The following is a description of a gene set: from publication Lee JS, Scandiuzzi L, Ray A, Wei J, Hofmeyer KA, Abadi YM, Loke P, Lin J, Yuan J, Serreze DV, Allison JP, Zang X (PMID 22972920) Genes up-regulated in pancreatic CD8 T cells from mice with: type 1 diabetes mellitus versus healthy controls. B7x (B7-H4 or B7S1) is the seventh member of the B7 family and the in vivo function remains largely unknown. Despite new genetic data linking the B7x gene with autoimmune diseases, how exactly it contributes to peripheral tolerance and autoimmunity is unclear. Here we showed that B7x protein was not detected on antigen-presenting cells or T cells in both human and mice, which is unique in the B7 family. As B7x protein is expressed in some peripheral cells such as pancreatic b cells, we utilized a CD8 T cell-mediated diabetes model (AI4ab) in which CD8 T cells recognize an endogenous self-antigen, and found that mice lacking B7x developed more severe diabetes than control AI4ab mice. Conversely, mice overexpressing B7x in the b cells (Rip-B7xAI4ab) were diabetes free. Furthermore, adoptive transfer of effector AI4ab CD8 T cells induced diabetes in control mice, but not in Rip-B7xAI4ab mice. Mechanistic studies revealed that pathogenic effector CD8 T cells were capable of migrating to the pancreas but failed to robustly destroy tissue when encountering local B7x in Rip-B7xAI4ab mice. Although AI4ab CD8 T cells in Rip-B7xAI4ab mice and AI4ab mice showed similar cytotoxic function, cell death, and global gene expression profiles, these cells had greater proliferation in AI4ab mice than in RIP-B7xAI4ab mice. These results suggest that B7x in nonlymphoid organs prevents peripheral autoimmunity partially through inhibiting proliferation of tissue-specific CD8 T cells and that local overexpression of B7x on pancreatic b cells is sufficient to abolish CD8 T cell-induced diabetes. species: Homo sapiens Human Gene Set: GSE40225_WT_VS_RIP_B7X_DIABETIC_MOUSE_PANCREATIC_CD8_TCELL_UP, and this is the list of marker genes: RNASEH2B, HNRNPA1, EVL, CELF1, PLSCR1, BACH2, RIPOR1, ZNF528, GALNT7, MAJIN, KLHL36, KCNG1, CRIP3 (NCBI Gene Id 401262), PCSK7, ZNF557, RNF130, PARP12, ZC3HAV1, SELENON, PDE8A, SESN3, VEZF1, SP140L, ZNF358, DOCK11, NSD3, BRAF, LIPA, AMPD3, PARP14, SLC30A4, POLM, CYP2U1, TMED8, GBP4, RALGPS2, DENND4C, TRIM44, AP4S1, TRAK2, SEMA4F, WDR5B, PTPN6, ESD, LAT2, TLK1, KDM1B, FMNL3, STAT5A, DOCK2 (dedicator of cytokinesis 2), USF3, KMT5B, ABL2, FCMR (NCBI Gene Id 9214), CLCF1, SAYSD1, SGSM3, RBM6, ZFYVE19, MID1IP1, BMP2K (NCBI Gene Id 55589), SNX10 (NCBI Gene Id 29887), RAB11FIP1, FBXW4P1, APLP2, SWAP70, SENP7, ST3GAL1 (ST3 beta-galactoside alpha-2,3-sialyltransferase 1), PUM1, SMG1, SNORA14B (small nucleolar RNA, H/ACA box 14B), USP44, TAS2R10, SP4, ZNF471, ETS1, SNX27, LARS1, FLT1, MSL2, LRRC56, PIK3C2B, SLC2A1, RB1, ZSCAN29, ZBTB10, EXOC2, UBE2E2, TSC22D3, ZNF28, RASGRP2, ENPP1, CDK5R1, SIPA1L1, SHPRH (SNF2 histone linker PHD RING helicase), CYBB, SLC6A16, COLGALT1, ZNF600, TTC32, IL4R, TAPT1-AS1, AIDA, ZFYVE27, NUDCD3, KHDRBS2, RABGAP1, NR3C2, IFNGR2, ABCC5, ZNF619 (zinc finger protein 619), ANKRD44 (ankyrin repeat domain 44), RAB12, KANSL1L, SORL1, SNORA50A, TRMT2B, CTNND1, PLEKHF2, DZIP3, OGA, CCNY, DTNB, ZNF300, ZNF880, DTX1, FCHSD2, JADE2, DTX4, VNN2, CHL1, ZNF468, AGBL2, SNORA57 (NCBI Gene Id 692158), CLCN4, RASA1, TAS2R19, CHD7, ATAD2B, CD1D, ZDHHC2 (NCBI Gene Id 51201), SERPINB9P1, FBXO11, SNORD116-15, PUM2, ST3GAL3, UTP25, RTN4IP1, VPS13C, RNF216, OSTF1, SCARNA6, ATP6V1H, TTC13, PCNX2, ADAM28, FCRLA, SLA, KLF16, JAK3, PTGS1 (NCBI Gene Id 5742), EFCAB13, ZDHHC23, ZNF844, SUSD6, OBI1, NUMA1, GSAP, TANGO6, TTC21A, PHKA2, LPGAT1, YJU2B, CHPT1, INPP5D, EPG5, MIR600HG, TSPAN33, CDKL1, DEAF1, ZNRF2 (zinc and ring finger 2), PSIP1 (PC4 and SRSF1 interacting protein 1), SNRK, SNORD12C, ZNF789, SEMA3D, DISP1, CAMK1D (NCBI Gene Id 57118), DDX39B (DExD-box helicase 39B), CD79B, ZNF571, ZNF678, CHIC1, MACF1, SMC6, SLC38A11, TBC1D10A, MIR223, THADA